Given this list of marker genes N4BP2, ESR2, DAZAP1, TCAP (titin-cap), KCNA1, OR5AR1, SPTSSB, HLA-DMB, PKP1, PPP1R16A, GPRC6A, SSBP3-AS1, FRRS1, SRGAP1, GLRX5, NAALADL2, MLC1, ASXL3, RSPO3, WDTC1, PAGE3, CYFIP1, AKR7A2, CD300LD-AS1, ELOVL4, TRAF5, MMP10, ICMT-DT, UNG, VPS18, NOC4L, KRTAP13-3, MMRN1, LDB2, MUC21, TAS2R4, TMEM267, KRT76, SPHK2, ID3, HLA-DQA1, LRP5, TVP23A, RNF145, SLC35B4, PTCD2, DLL1, ZNF549, P3H2, OR51M1, CDPF1, SLC8A1, MSX2, GPR15, ATP5F1C (NCBI Gene Id 511), CRACR2B, ZNF662, OR5H14, TFB2M, LGALS2, NACA2, PCBP4, MCU, MKS1, SCAMP5, SYCN, TCEAL5, CDH17 (NCBI Gene Id 1015), SNORA60, CLEC4A, HYCC2, GALR2, GPR34, ENPEP, PTK2, NCF2, IL12RB2, MUC2, CD300LF, PI15, PTPRD, CCN4, POU2F1, GLRA4, SIRT5, KIF2B, GID4, CSF1R, AATBC, PSRC1, G6PC1, LY9, ADM, UNC5A, PIK3R6, MDN1, NRBP1 (nuclear receptor binding protein 1), ERICH1, BARX1, KCNJ5, TCEAL7, SCUBE1, INMT, HEPH, KCNIP4, DOLK, EPN1, DNAH5, SEMA3D, PABPC1P2, CEBPE, SLC25A22, UNKL, PDE4B, CDCA7, ARHGEF37, SRSF6, PPP1R13B, NME7, SLC5A3, ACTR3B, SUGT1P1, UBE2L6, TOR3A, SRM, TMEM26, COMTD1, ZNF214, CD84, CFHR4, OR6N2, H3-3B, CCHCR1, TRMT1L, NUGGC, UNC5CL, STARD9, PDLIM3, MYL1, RETREG3, CYP27A1, CALCRL, COTL1, NEFH, HSPB3, ADAM28, MIR30B, BICD1, UBASH3B, CREG1, INSYN2A, IGBP1P1, C1orf162, STEAP4, SHISA3, VPS33B, HIVEP1, KRT15, CRACD, UTP14A, LRRC15, GCM1, SYNM, ETS2-AS1, SLC24A1, ZNF8, NRSN1, MACROH2A2, SPACA4, DZIP3, OR2G3, GVQW3, SIRPB1, APOA2, COL4A5, GUCD1, H2AC4, CTNNBIP1, CEP162, ADGRG2, ADAM3A, TUBD1, GCN1, RBMS3, NUDT8, BPIFC, OSBPL10, FBXO40, LRRTM4, CLVS2, TAPT1, TXNRD1, OR6S1, ENPP6, HYAL1, here is a description of the gene set: studied in species Homo sapiens Genes down-regulated in decidual macrophages with ITGAX high versus low. Human Gene Set: GSE22342_CD11C_HIGH_VS_LOW_DECIDUAL_MACROPHAGES_DN from publication Houser BL, Tilburgs T, Hill J, Nicotra ML, Strominger JL (PMID 21257965) Decidual macrophage populations, CD11cHI and CD11cLO cells were analyzed for expression profiles and unique characteristics. We used microarrays to detail the global program of gene expression and to determine differences between these two unique decidual macrophage populations.